Given this list of marker genes PIK3R2, AKT3, PIK3R6, PIK3CG, AKT2, MAPKAP1 (NCBI Gene Id 79182), THEM4, PIK3R5, RICTOR, PIK3CD, PIK3CB, MLST8, MAP3K14 (mitogen-activated protein kinase kinase kinase 14), TRIB3, CD86, PIK3R1, PIK3R3, MAP3K8, LCK, PIK3CA, MTOR, AKT1, CD28, FYN, PRR5, PDPK1, CD80, here is a description of the gene set: Human Gene Set: REACTOME_CD28_DEPENDENT_PI3K_AKT_SIGNALING CD28 dependent PI3K/Akt signaling species: Homo sapiens